Given this list of marker genes EPHA10, MYH10, EFNA4, SRC, EPHA3, LYN (NCBI Gene Id 4067), EFNA5, ROCK2, EPHA5, FYN, EPHA8, ROCK1, MYH11, MYL6, MYL12B, NGEF, EPHA7, EPHA2 (NCBI Gene Id 1969), YES1, EPHA1, MYH9, EFNA2, EFNA1, EFNA3, MYH14, EPHA6, MYL9, RHOA, EPHA4, here is a description of the gene set: species: Homo sapiens Reactome Pathway: EPHA-mediated growth cone collapse EPH/Ephrin signaling is coupled to Rho family GTPases such as Rac, Rho and Cdc42 that connect bidirectional receptor-ligand interactions to changes in the actin cytoskeleton (Noren & Pasquale 2004, Groeger & Nobes 2007). RHOA regulates actin dynamics and is involved in EPHA-induced growth cone collapse. This is mediated by ephexins. Ephexin, a guanine nucleotide exchange factor for Rho GTPases, interacts with the EPHA kinase domain and its subsequent activation differentially affects Rho GTPases, such that RHOA is activated, whereas Cdc42 and Rac1 are inhibited. Activation of RHOA, and inhibition of Cdc42 and Rac, shifts actin cytoskeleton to increased contraction and reduced expansion leading to growth-cone collapse. The activation of EPH receptors in growing neurons typically, but not always, leads to a growth cone collapse response and retraction from an ephrin-expressing substrate. EPHA-mediated repulsive responses prevent axons from growing into regions of excessive ephrin-A concentration, such as the posterior end of the superior colliculus. part of: EPH-Ephrin signaling